Given this list of marker genes Klf6, Klf2, Smad7, Satb1, Junb, Emp3, here is a description of the gene set: Cytokines mediate cell-cell communication in the immune system and represent important therapeutic targets. A myriad of studies have highlighted their central role in immune function, yet we lack a global view of the cellular responses of each immune cell type to each cytokine. To address this gap, the authors created the Immune Dictionary, a compendium of single-cell transcriptomic profiles of more than 17 immune cell types in response to each of 86 cytokines (>1,400 cytokine-cell type combinations) in mouse lymph nodes in vivo. A cytokine-centric view of the dictionary revealed that most cytokines induce highly cell-type-specific responses. For example, the inflammatory cytokine interleukin-1β induces distinct gene programmes in almost every cell type. A cell-type-centric view of the dictionary identified more than 66 cytokine-driven cellular polarization states across immune cell types, including previously uncharacterized states such as an interleukin-18-induced polyfunctional natural killer cell state. Mouse Gene Set: CUI_T_CELL_GD_IFNG_RESPONSE_DN from publication Cui A, Huang T, Li S, Ma A, Pérez JL, Sander C, Keskin DB, Wu CJ, Fraenkel E, Hacohen N (PMID 38057668) studied in species Mus musculus Genes negatively differentially expressed in cell type: γδ T cell upon treatment with cytokine: IFN-γ in mouse lymph nodes in vivo.